Given this list of marker genes FGFBP1, FGF2, FGFR2, FGFBP2, FGF1, FGF7, FGF22, FGFBP3, FGF3, FGF10, here is a description of the gene set: part of: FGFR2 ligand binding and activation Reactome Pathway: FGFR2b ligand binding and activation This pathway depicts the binding of an experimentally-verified range of ligands to FGFR2b. While binding affinities may vary considerably within this set, the ligands listed have been established to bring about receptor activation at their reported physiological concentrations. species: Homo sapiens